Given this list of marker genes Rae1, Nup205, Nup54 (NCBI Gene Id 269113), Snrpg, Nup85, Smn1, Gemin7, Seh1l, Gemin2, Nup42, Aaas, Gemin5, Nup210, Nup93, Nup155, Prmt5, Ndc1, Nup58, Snupn, Snrpf, Ddx20, Nup133, here is a description of the gene set: species: Mus musculus This event has been computationally inferred from an event that has been demonstrated in another species.<p>The inference is based on the homology mapping from PANTHER. Briefly, reactions for which all involved PhysicalEntities (in input, output and catalyst) have a mapped orthologue/paralogue (for complexes at least 75% of components must have a mapping) are inferred to the other species. electronically inferred by orthology from the curated human pathway part of: Metabolism of non-coding RNA Reactome Pathway: snRNP Assembly